Given this list of marker genes Pramel1, Larp4b, Vax2, AI597479, Sos1, Zfp985, Shisa2, Tspyl1, Eef2, Prpf4b, Plagl1, Nxph1, Adcy1, Rspo2 (R-spondin 2), Frmd4a, Hycc2, Tfpi2, Ss18, Epsti1, Ccdc167, Dlst, Zic1, Dcun1d5, Grb10, Rasgef1b, Tubgcp6, Slc17a2, Pkig, Foxo3, Nr2f6, Xlr5b, Mmp12, B4galt3, Rock2, Tspan3, Dynll1, Glb1, Sh3glb1 (SH3-domain GRB2-like B1 (endophilin)), Omp, Cradd, Cfap126, Taco1, Mapk6, Zfp704, Tab3, Ndst1, Slc35d1, Esco1, En1, Peg3, Xlr5a, Rspo4, Dab2ip, Slc16a13, Prrx1, Cxcr4, Dpp10, Hbq1b, Krtap7-1, Ephb3, Acsl4, Mrpl35, Csnk1e, Lpp, Appl1, Mrpl13, Calu, Eri1, Art1, Dock11, Wasl, Syncrip, Muc20, Slc36a1, Cmpk1 (NCBI Gene Id 66588), Cd276, Or51e1, Med12, Nrsn1, Clcn3, Eif4e, Ube2k, Vps37a, Zfand5, Atg14, Kel, Epha5, Gpr101, Zmat2, P4ha1, Sdf2l1 (NCBI Gene Id 64136), Cnp, Synj2bp (NCBI Gene Id 28115), Hhex, 9430015G10Rik, Retreg1, Slc38a1, Ppp1r2, Cntnap2, Foxp3 (NCBI Gene Id 20371), Elovl7, Nol4l, Trim45, Tsc1 (NCBI Gene Id 64930), Wfikkn2 (NCBI Gene Id 70468), Cyp2j13, here is a description of the gene set: Genes predicted to be targets of miRBase v22 microRNA mmu_miR_452_3p in miRDB v6.0 with MirTarget v4 prediction scores > 80 (high confidence targets). species: Mus musculus Mouse Gene Set: MIR_452_3P from publication Chen Y, Wang X (PMID 31504780)